The following is a description of a gene set: Catalysis of the reaction: a 2'-deoxyribonucleoside 5'-triphosphate + DNA(n) = diphosphate + DNA(n+1); RNA-template-directed extension of the 3'-end of a DNA strand by one deoxynucleotide at a time. Human Gene Set: GOMF_RNA_DIRECTED_DNA_POLYMERASE_ACTIVITY studied in species Homo sapiens, and this is the list of marker genes: PINX1, POT1, PTGES3, ACD, PIF1, TERT, MCRS1, TEN1, ERCC4, TERF2, TEP1, TERC, DKC1, POLQ, TERF1